Given this list of marker genes TIMM13, TIMM29, MTX1, TOMM6, TRMT10B, NDUFA13, AP3B1, TOMM70, BCS1L, TOMM40, CALM3, TOMM5, TIMM10B, AGK, TIMM9, BAX, MOAP1, ROMO1, TOMM22, SAMM50, COX18, MTCH1, TIMM10, TIMM8A, MAIP1, MTX2, OXA1L, TMEM126A, TOMM20, TIMM22, TIMM8B, MTCH2, TOMM7, here is a description of the gene set: The directed movement of a protein to a specific location in the mitochondrial membrane. Human Gene Set: GOBP_ESTABLISHMENT_OF_PROTEIN_LOCALIZATION_TO_MITOCHONDRIAL_MEMBRANE species: Homo sapiens